Given this list of marker genes NOS1 (NCBI Gene Id 4842), CYP27A1, CYP26A1, FMO4, CYP27B1, CYP3A4 (NCBI Gene Id 1576), CYP2A6, CYP2J2, CYP1B1, BBOX1, CYP2C18, HMOX2, CYP3A7, CYP2B6, CYP2E1, CYP2C8, PAH, CYP11A1, CYP1A1, CYP4A11, CYP4B1, CYP2D6, CYP11B2, FMO3, CYP2C19, here is a description of the gene set: Human Gene Set: MODULE_135 species: Homo sapiens Genes in the cancer module 135.